Given this list of marker genes Sdhd, mt-Nd4, Dhodh, Sdhb, Coq10b, Etfdh, here is a description of the gene set: species: Mus musculus Mouse Gene Set: GOMF_UBIQUINONE_BINDING Binding to ubiquinone, a quinone derivative with a tail of isoprene units.